The following is a description of a gene set: from publication Cui A, Huang T, Li S, Ma A, Pérez JL, Sander C, Keskin DB, Wu CJ, Fraenkel E, Hacohen N (PMID 38057668) species: Mus musculus Genes positively differentially expressed in cell type: Macrophage upon treatment with cytokine: IL-1β in mouse lymph nodes in vivo. Mouse Gene Set: CUI_MACROPHAGE_IL1B_RESPONSE_UP Cytokines mediate cell-cell communication in the immune system and represent important therapeutic targets. A myriad of studies have highlighted their central role in immune function, yet we lack a global view of the cellular responses of each immune cell type to each cytokine. To address this gap, the authors created the Immune Dictionary, a compendium of single-cell transcriptomic profiles of more than 17 immune cell types in response to each of 86 cytokines (>1,400 cytokine-cell type combinations) in mouse lymph nodes in vivo. A cytokine-centric view of the dictionary revealed that most cytokines induce highly cell-type-specific responses. For example, the inflammatory cytokine interleukin-1β induces distinct gene programmes in almost every cell type. A cell-type-centric view of the dictionary identified more than 66 cytokine-driven cellular polarization states across immune cell types, including previously uncharacterized states such as an interleukin-18-induced polyfunctional natural killer cell state., and this is the list of marker genes: Ncl, Imp4, Xbp1 (NCBI Gene Id 52219), Atp6v1b2, Ccl6, Lyve1, Plaur, Tuba1c, Hspd1, Bach1, Eef1e1, Orai1, Bcl2a1a, C5ar1, Fcgr3, Lrrc59, Cebpd, Nhp2, Etf1, Gtpbp4, Ly86, Cycs, Txnrd1, Efhd2, Ifi204, Glrx, Scimp, Pik3r5, AA467197, Tubb6, Actr3, Snrpd1, Set, Mafb, Ccl24, Ccl9, Nop56, Pnp (purine-nucleoside phosphorylase), Tfec, Ube2s, Rrs1, Cd274 (CD274 antigen), Ppp2ca, Lyn, Tpm4, Mt2, Hmox1, Srm, Rsl24d1, Ran, Hbegf, Ifitm2, Bzw2, Wfdc17, Ddit4, Palld, Prkcd, Glipr2, Anp32b, Pdcd1lg2, Tmed5, Susd6, Fabp5, Ppan (NCBI Gene Id 245822), Timm9, Tuba1b, Sdc4, Il1b, Ddx21, Eif3a, Osgin1, Casp8, Junb, Cebpb (NCBI Gene Id 18031), Il1rn, Cd209e, Riok3, Ccl12, Lgals3, Timm8a1, Rab20, Hilpda, Slfn8, Hspa9, Slfn2, Rrp1, Otud4, Egr1, Pak1ip1, Gpt2 (glutamic pyruvate transaminase (alanine aminotransferase) 2), Serbp1, Nop58, Rars1, Dab2, Bcl2a1d, Eps8, Ptpn1, Ifi211, Dusp2, Steap4, Litaf, Klf9, Tma16, Tomm20, Msr1, Dok2, Socs2, Chchd4, Ifitm3, Actg1, Hs3st3b1, Filip1l, Ak2, Wnk1, Wdr12, Mrap, Il4ra, Myl12a, Procr (NCBI Gene Id 98921), Ddx39a, Gch1, Eif5a (eukaryotic translation initiation factor 5A), Pim1, Fcgr2b, Odc1 (NCBI Gene Id 18263), Pfdn4, Gk, Eif1, Ranbp2, Tgm2, Ctnnd1, AI987944, Prpf31, Ms4a6b, Fyn, Ccl7, Srgn, Socs3, Ifi207, Bcl2l1, Rnf149, Plek, Lgmn, Clec4n, Agfg1, Dkc1, Plin2, Cfl1, Clic4, Ssh2, Eif4a1, Uck2, Mt1, Anxa7, Serpina3g, Rgs1, Ranbp1, Jaml, Sod2, Ybx3, Lilrb4b, Ms4a6d, Rbms1, Eif1a, Ap2a2, Csrp1, Stat3, Rin2, Bcl2a1b, Ccl2, Fkbp5, Cd53